The following is a description of a gene set: Sperm with cigar-shaped heads that gradually dimish in diameter (taper). Tapered sperm head Human Gene Set: HP_TAPERED_SPERM_HEAD species: Homo sapiens, and this is the list of marker genes: CFAP69, CATIP, IQCN, DNAH17, ACTL9 (actin like 9), CFAP70, ARMC2 (armadillo repeat containing 2), TTC29